Given this list of marker genes CEPT1, FKRP, SAMD8, PGS1, PIGN, PIGF, CDS1, CDIPT, CRLS1, AASDHPPT (aminoadipate-semialdehyde dehydrogenase-phosphopantetheinyl transferase), FKTN (fukutin), PIGG, SGMS2, PTDSS1, PIGO, SGMS1, DPAGT1, SELENOI, GNPTAB, PTDSS2, CHPT1, here is a description of the gene set: Catalysis of the transfer of a substituted phosphate group, other than diphosphate or nucleotidyl residues, from one compound (donor) to a another (acceptor). species: Homo sapiens Human Gene Set: GOMF_PHOSPHOTRANSFERASE_ACTIVITY_FOR_OTHER_SUBSTITUTED_PHOSPHATE_GROUPS